Given this list of marker genes KRT15, LGALS7, COL3A1, CPB1, LAMA5, LAMA4, HNF1B, LAMA3, LAMC1, LORICRIN, CASP14, YAP1, COL5A1, VTN, COL5A3, LAMC2, TFRC, PRSS3, SYCN, PTF1A, FLG, KLK5, COL2A1, CA2, COL24A1, PROM1, KRT7, KRT24, KRT1 (NCBI Gene Id 3848), CTRC, SOX17, AQP1, CPA1, KLK1, ONECUT1, PLA2G1B, BHLHA15, ANXA3, LAMB3, CSPG4, HHEX, ERICH5, LAMB1 (laminin subunit beta 1), COL1A1, PDX1, CELA3B, AMY2A, DLL1, SPINK1, KRT14, GATA4, GNMT, ITGA6, LAMA1, GP2, KRT10, FOXA2, DMKN, KPRP, TFPI2, CXCR4, CALML5, RNASE1, COL5A2, AQP3, SLC4A4, FABP5, PRSS1, COL27A1, COL1A2, PNLIPRP2, KRT19, SHH, CFTR, EGF, LAMB2, ABCG2, PNLIP, KRTDAP, GATA6, CELA2A, SPINK5, TP63 (tumor protein p63), NKX6-1, HOPX, CLDN10, LGALS7B, SERPINA4, KRT23, AQP8, NUMB, IVL, ANXA1, COL11A2, FGF4, SBSN, REG1A, FGF7, CTRL, CD74 (NCBI Gene Id 972), ITGB1, GJB3, KRT5, FGF2, LAMA2, CEL, COL11A1, LAMC3, ITGB4, CPA2, FN1, KRT17, KLK7, KRT78, SPRR2A, CER1, ANXA2, PDIA2, LRIG1, SOX9, FGF10, here is a description of the gene set: species: Homo sapiens Human Gene Set: REACTOME_DEVELOPMENTAL_CELL_LINEAGES Developmental Cell Lineages